Given this list of marker genes LINC02693, KCTD10, CTCFL, SLC24A3, APAF1, CELF4, LMO4, RNF213, KDM7A, RAB10, NXF3, SLC30A5 (NCBI Gene Id 79021), STOX2, CTDSP1, UGCG, OSBPL2, GIPC2, GEMIN8, PTAFR, SMIM43, ALKBH8, P4HA2, MT1E, KCNC2, SHANK2, HES1, RAB39B, ZNF655, NEXMIF (NCBI Gene Id 340533), MLEC, SRGAP1, TAF12, NDRG4, PAGE4, ST8SIA3, ZNF518A, NIPSNAP2, RASSF4, TMEM179, GRIA2, GATA6, GPC6, RAB9B, THBS1 (NCBI Gene Id 7057), PHTF2, ZFC3H1, ATG12, SCP2, ARHGAP44, EGLN1, GLT8D2, CABP7, KLF2, FGF5, VPS53, DDX3Y, PROX1, UBXN7, LAMB4, TRPM3, GSK3B, ZNF608, NRG4, PBDC1, PHAF1, USP13, XPO7, RNF168, RGS7BP (NCBI Gene Id 401190), DNMT3A, ATRX, UQCC1, PRUNE1, MFSD5, ZNF621, SLC23A2, PNMA8A, HMGCR, CPEB2, CCDC50, RAB14, KRTCAP3, HNRNPR, ASXL2, EGR1, CCN4, FAM167A, RUFY3, GLIPR1L2 (NCBI Gene Id 144321), DDX3X, CNOT7, CTBP1, ABCG5, MFSD4B, CDR2, TOP1, LEP, SELENOS, ORMDL1, CNP, NFAT5, IFNB1, EPHB1, ZBTB46, DYRK1A, CTBP2, OR2A4, LMAN2L, MBTD1, DLG3, CCDC178, VIPAS39, RALBP1, TRIM66, BPGM, GVQW3, PPP1R12A, ATG4A, DDX60, SNAP91, CACNA1G, GPATCH2, PTPRE (NCBI Gene Id 5791), UXS1, ZNF189, GATD3, ZFP36L2, HNRNPDL, RASSF8, ARAP2, SETD5, GTF2H5, CLTB, GIGYF1, RALA, RRN3, CCDC32, ABCC4, NUP153, TIMM9, ASXL3, PPME1, TNFAIP8, TMEM70, PLEKHA1, ZMYND8, MMP10, HMGCS1, RBM45, here is a description of the gene set: from publication Chen Y, Wang X (PMID 31504780) Genes predicted to be targets of miRBase v22 microRNA hsa-miR-4704-3p in miRDB v6.0 with MirTarget v4 prediction scores > 80 (high confidence targets). Human Gene Set: MIR4704_3P species: Homo sapiens